The following is a description of a gene set: studied in species Homo sapiens Childhood acute lymphoblastic leukemia (ALL) is curable with chemotherapy in approximately 80 percent of patients. However, the cause of treatment failure in the remaining 20 percent of patients is largely unknown. Human Gene Set: HOLLEMAN_VINCRISTINE_RESISTANCE_ALL_DN Genes distinguishing vincristine resistant and sensitive ALL (B- and T-lineage ALL); here - genes down-regulated in the drug resistant samples. from publication Holleman A, Cheok MH, den Boer ML, Yang W, Veerman AJ, Kazemier KM, Pei D, Cheng C, Pui CH, Relling MV, Janka-Schaub GE, Pieters R, Evans WE (PMID 15295046), and this is the list of marker genes: RPS15A, RPS12, HNRNPU, TMSB10, RPL31 (ribosomal protein L31), INTS1, LSM7, HMGB1, ATP13A2, RPL12, VIM, RASGRP2, SCNM1, MAN2B1, RPS2, NME2, RPLP2, RPL23A, RPS24, CD44